Given this list of marker genes CTNNB1, PPP2R1A, CSNK1A1, PPP2R5E, AXIN1, GSK3B, APC, PPP2CA, AMER1, PPP2CB, PPP2R5A, PPP2R1B, PPP2R5D, PPP2R5C, PPP2R5B, here is a description of the gene set: Signaling by CTNNB1 phospho-site mutants studied in species Homo sapiens Human Gene Set: REACTOME_SIGNALING_BY_CTNNB1_PHOSPHO_SITE_MUTANTS